The following is a description of a gene set: Genes up-regulated in lymphocytes treated with medium for 24h: T conv versus T reg cells. Here we show that tumor necrosis factor (TNF) induced in human T-regulatory cells (Treg), as compared to conventional T cells (Tcon), a transcription program highly enriched for typical NF-κB target genes, such as: the cytokines LTA and TNF; the TNF-receptor super family members FAS, 4-1BB and OX-40; various anti-apoptotic genes; and other important immune-response genes. As an initial approach to examine the cellular program induced by TNF in Tregs versus Tcon cells, we employed microarray gene expression analysis at 2 and 24 hrs following TNF treatment. Human Gene Set: GSE18893_TCONV_VS_TREG_24H_CULTURE_UP from publication Nagar M, Jacob-Hirsch J, Vernitsky H, Berkun Y, Ben-Horin S, Amariglio N, Bank I, Kloog Y, Rechavi G, Goldstein I (PMID 20181891) species: Homo sapiens, and this is the list of marker genes: LCP2, RAP1GAP, ANXA5, GRAMD1B, ITGB1, PLAUR, NID1 (nidogen 1), PWP1, LINC01160, B4GALT1, TG, ASS1, CHST12, PEA15, SBF2, LMO2, STAC2, KCNAB2, TFAP4, GUCD1, ECHDC3, KLHL9 (NCBI Gene Id 55958), EMP3, SLC29A4, ADD1, S100A5, ACP5, NFE2, CD68, EID2, GDAP1, CRMP1, GIMAP4, TJP1, SLC34A1, CACNA1S, AKR7A2, LYSMD2, SPACA9, DOK2, S100A10, GART, INPP4A, PTGER4, EBPL, RHOBTB1, DUSP3, SFXN3, ZBTB32, NRP2, TWSG1, ACSS1, LGALS3, AFF3, PEPD, SLC7A1, NEO1, PLP2, GPR137B, TBC1D9, CAPG (NCBI Gene Id 822), PHYHD1, SNAP29, SSBP4, ARHGEF16, OSTF1, JCHAIN, RFK, PRKCZ, SIRT2, GPR183, SNN, MCUB, LIME1, TMEM51, ZDHHC2, FXYD5, IGSF8, ANXA2, RAP1GAP2, HEPACAM2, MCU, DKKL1, ADGRE5, S100A6, CRIP1, ACAD8, PDLIM1, ST6GAL1, PLEKHB2, CYTH3, RDH12, TPD52 (tumor protein D52), PIK3R2, ITPR1, RFX2, SIPA1L1, LRRC75A, FAM98C, BDH1, GIMAP7, RASSF4, SGK1, SLC25A15, SOX5, PDCD1LG2, ECH1, KCNN4, ANXA1, B4GALT6, CDC42BPB, ADORA2A, RGMB, THYN1, MAPK12, PRKAR2A, KCTD14, AHNAK2, FAM89A, NFIX, TNFRSF13B, ARRB1, INKA1, INTS4, AHNAK, LITAF, LIFR, IMMP2L, TNFRSF1B, PPP1R14B (protein phosphatase 1 regulatory inhibitor subunit 14B), S100A4 (NCBI Gene Id 6275), STX7, RYK, PARM1, ANXA7, CD48, UPB1, GRB7, CD80, GOLM1, NADK, NR3C2 (NCBI Gene Id 4306), MXRA8, GNS, IGHG1, PLSCR1, GLIPR2, RAB3B, AFDN, TCP11L2, HSPB1, SORCS2, MARVELD1, TMEM41A, VIM, RBPJ, TMEFF1, MEGF8 (NCBI Gene Id 90198), PDE8A, KLHL25, FCGRT, CD274, ZBTB42, CHST7, SLAMF9, GRAMD4, ANXA6, EXTL1, RNASE4, TAGLN2, ITGB7, TUB, NEUROD4 (NCBI Gene Id 58158), ADSS1, SMPDL3A, ABCA3, TBRG1, BIN1, TUBB6, RINL, TMCC3, CKAP4, AK8, ITSN1, PRKX, LIMA1, PAFAH1B3, HLCS, RCN3, ENTPD5, LGALS1, SLC39A11, RTN4RL1, MYADM, RASA3, AP1S2, TLE3, GPX1, TPPP, CRIP2